The following is a description of a gene set: The reciprocal chromosomal translocation t(4;11) is correlated with infant, childhood, adult and therapy-related high-risk acute leukemia. Here, we investigated the biological effects of MLL.AF4, AF4.MLL or the combination of both reciprocal fusion proteins in a conditional in vitro cell culture model system. Several parameters like cell growth, cell cycling capacity, apoptotic behavior and growth transformation were investigated under physiological and stress conditions. Co-transfected cells displayed the highest resistance against apoptotic triggers, cell cycling capacity and loss-of-contact inhibition. These analyses were complemented by gene expression profiling experiments and specific gene signatures were established for each of the three cell lines. Interestingly, co-transfected cells strongly upregulate the homeobox gene Nanog. In combination with Oct4, the Nanog homeoprotein is steering maintenance of pluripotency and self-renewal in embryonic stem cells. Transcription of Nanog and other stem cell factors, like Oct4 and Bmi1, was verified in biopsy material of t(4;11) patient cells which express both reciprocal t(4;11) fusion genes. In conclusion, the presence of both reciprocal MLL fusion proteins confers biological properties known from t(4;11) leukemia, suggesting that each of the two fusion proteins contribute specific properties and, in combination, also synergistic effects to the leukemic phenotype. species: Mus musculus from publication Gaussmann A, Wenger T, Eberle I, Bursen A, Bracharz S, Herr I, Dingermann T, Marschalek R (PMID 17130830) Human Gene Set: GAUSSMANN_MLL_AF4_FUSION_TARGETS_C_UP Up-regulated genes from the set C (Fig. 5a): specific to cells expressing AF4-MLL fusion protein alone., and this is the list of marker genes: BRDT, ZC3H11A, NKTR, UGDH, TSNAXIP1, PDLIM5, NEMF, CXCL10, B4GALNT1, METTL27, SDC1, PUF60, YIPF4, NFKBIE, FKBP7, IFITM1, COX11, STAT3, CRYBG1, MSLN, IFNAR1, HSPA1A, BUB3, MFSD8, ITGA1, CHMP5, SLC11A2, SCRN3, CA9, GPR45, KANK3, FOXN3, NCK1, SLC12A6, SACM1L, IFITM3, YIPF2, DPY19L3, RFX3, TLL1, LACC1 (NCBI Gene Id 144811), PPP1R13B, PLEC, FAM20A, TCL1B, ZNF182, TNFRSF19, PPP1R16A, BNIP2, CPT1A, STAG1, CGAS, NEUROD1, LRRC63 (NCBI Gene Id 220416), PHIP, INO80, MACROH2A2, LRCH1, COTL1, LYSMD1, SNX13, KLF12, ACTN3, TP73, RPS15A, B3GAT3, HYPK, TRPM5, PSMD7, PTPRD, WDR6, DAPP1, NEDD9, DDAH1, CLDN10, PER1 (period circadian regulator 1), CALU, FGD3, PDCD6IP, TXLNB, CASTOR2, ACAA1, NEK7, MALAT1, USP3, GGNBP2, DMP1, MAP3K1, BTF3L4, ERGIC2, COL5A1, NETO2, GLIS3, PDZD2, PRKAG1, SMR3B, BRD2, EMC7 (NCBI Gene Id 56851), RASSF3, B3GALT1, IER5L, CCDC125 (coiled-coil domain containing 125), SRSF11, LRIG1, RASL12, LPIN1, SOX7, PRP4K, FBXL3, MXRA7, DNMT3A, MIR100HG, RREB1, PLAU, MAP4K5, NES, PRPF40B, FKBP14, PDE1C, RPS6KA5, H2BC13, MIR22HG, NHERF2, TIMP3, PIK3CA (NCBI Gene Id 5290), TUBG2, ERBIN, ALG14, TCF4, TPK1, GPSM1, CSNK1A1, CTSF, SH3BGRL2, COL27A1 (collagen type XXVII alpha 1 chain), RBM10, NXN, RORA (NCBI Gene Id 6095), KCTD3, LFNG, DNAJC3, FLT4, TEC (tec protein tyrosine kinase), YWHAZ, PRPF38B, ZMAT2, SPEG, TMC6, RMND1, CDC42EP2, TOMM20, CCAR1, RPS20, TCF7, E2F6, PLD3, UNC13B, FAM13C, PPP1R3F, MRPS15, FAM149A, ZBTB38, MAP2K4, FAT4, LCORL, ECRG4, UBE2D3, ZIC3, PTHLH, RAB3IL1, FNDC3A, TENT2, MEOX1, RPRD2